The following is a description of a gene set: An mRNA stabilization process in which one or more RNA-binding proteins associate with a sequence in the open reading frame called the coding region instability determinant (CRD). Human Gene Set: GOBP_CRD_MEDIATED_MRNA_STABILIZATION studied in species Homo sapiens, and this is the list of marker genes: IGF2BP1, YBX1, SYNCRIP, HNRNPD, HNRNPU, PAIP1, IGF2BP2, PABPC1, IGF2BP3, DHX9, CSDE1